The following is a description of a gene set: species: Mus musculus Mouse Gene Set: GOBP_REGULATION_OF_MESODERMAL_CELL_DIFFERENTIATION Any process that modulates the frequency, rate or extent of mesodermal cell differentiation., and this is the list of marker genes: Dkk1, Fgfr1, Bmpr1a, Gja1, Bmp4, Wnt3a, Mesp1, Sfrp2